The following is a description of a gene set: Human Gene Set: GOBP_REGULATION_OF_T_HELPER_CELL_DIFFERENTIATION species: Homo sapiens Any process that modulates the frequency, rate or extent of T-helper cell differentiation., and this is the list of marker genes: TNFSF4, IL27, RIPK2, GPR65, IL23R, ASCL2, IL12B, CD69, CCL19, CD80, BCL6, ANXA1, NFKBIZ, IRF4, LGALS1, BATF, NLRP3, GATA3, MIR21, ZBTB7B, TNFSF18, IL23A, RC3H2, NFKBID, IL12RB1, RC3H1 (NCBI Gene Id 149041), PRKCZ, MALT1, CD86, BRD2, SHB, STAT5A, EP300, BRD4, ZC3H12A, HLA-DRB1, FOXP3, LOXL3, IL18, SMAD7, TBX21, IL4R, IL2, HLX, OPA1, SOCS5, JUNB (JunB proto-oncogene, AP-1 transcription factor subunit), JAK3, HLA-DRA, RARA